The following is a description of a gene set: from publication Belyaev NN, Biró J, Athanasakis D, Fernandez-Reyes D, Potocnik AJ (PMID 22581009) studied in species Homo sapiens Development of T-cells provides a unique opportunity to study cell-fate determination due to the accessability and the well defined stages of developmental stages. In order to understand the genetic programs underlying fetal and adult T‑cell fate specification we subjected highly purified fetal and adult T-cell progenitor populations to a genome‑wide transcriptional analysis. The aim was to identify molecular elements that govern T-cell fate specification as a whole but ultimately to isolate elements that were specific for a given population in a specific developmental window. Human Gene Set: GSE24142_EARLY_THYMIC_PROGENITOR_VS_DN2_THYMOCYTE_FETAL_UP Genes up-regulated in comparison of thymic progenitors versus fetal DN2 thymocytes., and this is the list of marker genes: ABCA1, PAIP2, CCR8, PYGL, REEP6, SKAP2, USP18, C11orf54, ESAM, GRB10, CPQ, GSTM3 (glutathione S-transferase mu 3), MCOLN3, TMEM119, GCSAM, SAMHD1, OGFRL1, TMEM71, DDX4, NR1D2, FGL2, TMEM176B, GEM, NRROS, TJP2, LPCAT1, ARL5A, RFLNB, TSPAN33, CD7, P2RY14, TTPA, YWHAH, CSF1R, ALOX15, CMTM3, SNX9, CLEC4E, TGIF2, PIGC, P2RX4, CCND1, VIM, CASP1 (caspase 1), PRCP, GCNT2, PYGM, IRF9, SULF2, PTPN12, RGS3 (regulator of G protein signaling 3), KLF1, B3GNT5, PTTG1IP, SGSH, MXD4, MT2A, EPS8, CD302, ARRB1, ST3GAL2, OTULINL, TSC22D1, ABCA3, MEF2C, PHKB, LGALSL, FFAR2, PTK2, KLRD1, PLEK, GCLC, METRNL, IER3, TSC22D3, MYCN, ICAM1, ITGA9, CCR9, CMTR2, NDN, HMGA2, S1PR1, ARHGAP12, HSPA5, PLXNB2 (plexin B2), LRRK1, CA2, APOBR, IFNG, B4GALT6, AVIL, GRK5, BIRC3, ARHGAP18, TNIP2, DENND5A, MPL, CFP, CD300LF, THEMIS2, PRTN3, SOCS5, DAB2IP, RAI14, HOXA9 (NCBI Gene Id 94575), KCTD14, MACROH2A1, ITIH5, IL1R1, MAN2B1, FASLG, TGM2 (NCBI Gene Id 7052), RAB31, RHD, SLC25A45, FHOD3, CTSS (cathepsin S), FSTL1, EHBP1L1, LMO2, PPP3CA (protein phosphatase 3 catalytic subunit alpha), IL18R1, FCRL1, IL10RB, RAB32, CD34, APPL2, CD44, SASH1, CXCR3, ADAMDEC1, CASD1, RAMP2, ACTG1, PIP4K2A, LYN, PPP1R2P1, PER2, TOR1B, TRIM34, ST6GALNAC3, MITF (NCBI Gene Id 7487), PLA2G4A, ABCB4 (ATP binding cassette subfamily B member 4), ITGB2, LBP, FLT3, PCYOX1 (NCBI Gene Id 63081), RGS8, SLA, RNF2 (ring finger protein 2), MYADM, AQP9, PTGS1, SNX19 (NCBI Gene Id 9795), ICA1, EEIG1, IL4R, PAK1, VCL, BEX4, IRF6, CD81, CDCA7L, TMEM51, CD86, ST6GAL1, SHISA2, HLA-C, SLCO3A1, SH3BP2, ZNF202, CD300A, CYB561, MEIS1, PLXNC1, CCR2, FCGR2A (Fc gamma receptor IIa), CD33, SIRPA (signal regulatory protein alpha), TCEAL1, OSBPL1A, BCL11A, POLR3GL, MPO, IGF2BP2, TNFSF14, TMEM185A, NIBAN2, TMEM63A, HEBP1, DNMT3B, IRF8, IGDCC4, DOCK7, OAS2, TAL1, FMO5, ADGRL4